The following is a description of a gene set: species: Mus musculus The process in which a Schwann cell membrane closes around an axon in the peripheral nervous system. This can be a myelinating or a non-myelinating neuron-glial interaction. Mouse Gene Set: GOBP_PERIPHERAL_NERVOUS_SYSTEM_AXON_ENSHEATHMENT, and this is the list of marker genes: Pals1, Nrg1, Prx, Slc25a46, Adam22, Ntrk3, Col6a1, Ncmap, Adgrg6, Nf1, Fa2h, Ntrk2, Cntnap1, Pmp22, Sh3tc2, Akt2, Itgb4, Sod1, Pi4ka, Akt1, Arhgef10, Pou3f1, Ilk, Pard3, Plec, Ski, Dicer1, Ndrg1, Sirt2, Lgi4, Myoc, Pou3f2, Dag1, Ppp3r1